Given this list of marker genes ROPN1B, HYAL3, ZP4, PCSK4, SYT6, SPINK1, ZP2, ABHD2 (NCBI Gene Id 654057), TNP2, STX2, PRSS37, SERPINA10, CRISP1, CCDC87, STXBP1, IFTAP, PLCB1, ADCY3, PLB1, LCN6 (NCBI Gene Id 377830), HVCN1, UNC13B, SYT8, PRND, ACR, EQTN, ZP3, RIMS1, FAM170B, GLRA1, AKAP3, PLCD4, RAB3A, IQCF1, B4GALT1, CACNA1H, PKDREJ, GLRB, SPINK13, PLA2G10, TRIM36 (NCBI Gene Id 55521), SPESP1, GARIN1B (golgi associated RAB2 interactor 1B), here is a description of the gene set: species: Homo sapiens The discharge, by sperm, of a single, anterior secretory granule following the sperm's attachment to the zona pellucida of the oocyte. The process begins with the fusion of the outer acrosomal membrane with the sperm plasma membrane and ends with the exocytosis of the acrosomal contents into the zona pellucida. Human Gene Set: GOBP_ACROSOME_REACTION